The following is a description of a gene set: Binding to a phospholipase. species: Homo sapiens Human Gene Set: GOMF_PHOSPHOLIPASE_BINDING, and this is the list of marker genes: PDPK1, SRC, STXBP1, SYK, BLNK, ARHGAP6, SELE, LCK, PRKN, APOC2, LMNB1 (NCBI Gene Id 445266), TESPA1, FYN, NEFL, BANK1, SRSF3, SNCA, CLEC6A, PLA2R1, PAFAH1B1, BTK, WAS, DGKQ